Given this list of marker genes Dvl2, Kat2a, Dvl3, Psen2, Dvl1, Maml1, Aph1b, Adam17, Maml3, Crebbp, Ncor2, Ctbp1, Notch2, Hdac1, Aph1a, Dtx2, Rfng, Dtx3, Numb, Mfng, Rbpj, Dll3, Lfng (LFNG O-fucosylpeptide 3-beta-N-acetylglucosaminyltransferase), Dll1 (NCBI Gene Id 13388), Psen1, Cir1, Dtx1, Hdac2, Notch3 (notch 3), Hes1, Snw1, Hes5, Numbl, Dtx3l, Notch1, Ncstn, Rbpjl, Jag1, Dtx4, Ctbp2, Notch4, Jag2, Tnf, Dll4, Kat2b (K(lysine) acetyltransferase 2B), Ptcra, here is a description of the gene set: Mouse Gene Set: WP_NOTCH_SIGNALING_PATHWAY Notch signaling pathway studied in species Mus musculus